The following is a description of a gene set: species: Homo sapiens Human Gene Set: GOCC_MICROVILLUS_MEMBRANE The portion of the plasma membrane surrounding a microvillus., and this is the list of marker genes: SLC7A8, ITGB3, CEACAM1, AMN1, CUBN, SLC7A11, SLC6A6, IZUMO1R, AMN, CDHR2, SYTL1, PDPN, PDZK1, SLC38A4, PODXL, DPEP1, EZR, PROM2 (NCBI Gene Id 200480), SLC26A2, CEACAM20, CA9, S100P, PTPRH, PROM1, MSN, MTTP, MUC20, CTNNB1, FCRL3, NHERF1, SLC7A5, CDHR5, ITGAV